Given this list of marker genes PLXNB1, ARHGEF11, MYH11, MYL12B, LIMK2, SEMA4D, RHOA, ARHGEF12, RND1, ERBB2, ROCK2, RHOC, MYH10, ROCK1, MYH14, MYL6, MYL9, MYH9, LIMK1 (LIM domain kinase 1), RHOB, here is a description of the gene set: species: Homo sapiens Sema4D induced cell migration and growth-cone collapse Human Gene Set: REACTOME_SEMA4D_INDUCED_CELL_MIGRATION_AND_GROWTH_CONE_COLLAPSE